The following is a description of a gene set: Human Gene Set: GSE2770_UNTREATED_VS_ACT_CD4_TCELL_2H_DN Th1 and Th2 cells arise from a common precursor cell in response to triggering through the TCR and cytokine receptors for IL-12 or IL-4. This leads to activation of complex signaling pathways, which are not known in detail. Disturbances in the balance between type 1 and type 2 responses can lead to certain immune-mediated diseases. Thus, it is important to understand how Th1 and Th2 cells are generated. To clarify the mechanisms as to how IL-12 and IL-4 induce Th1 and Th2 differentiation and how TGF-beta can inhibit this process, we have used oligonucleotide arrays to examine the early polarization of Th1 and Th2 cells in the presence and absence of TGF-beta after 0, 2, 6 and 48 hours of polarization. species: Homo sapiens Genes down-regulated in CD4 T cells: untreated (0h) versus activated by anti-CD3 and anti-CD28 (2h). from publication Lund R, Aittokallio T, Nevalainen O, Lahesmaa R (PMID 14607935), and this is the list of marker genes: PSMD3, PHKA1, DRG1, PELP1, FGFBP3, PCBP1, KLHL23, TSEN2, KCNK5, PAICS, KSR1, TANGO2, ANGPTL4, MTHFD1, PPIE, CCT3, SLX4, TERF1, SCRN3, FER, ARMCX2, DNAAF2, PRELID3B, CSTF3, E2F2, RTCA, NDUFAF7, NHP2, DPP9, DENND4C, HPS6, PSMC2, PEX2, EWSR1, SLC35F2, FAM83G, MSANTD4, UBA3, MEGF10, EXOSC10, GPHN, UBAP1, PARL, EIF4G2, MESD (NCBI Gene Id 23184), TFG, FARP2, AARS1, PDSS2, CAPRIN1, NUP58 (NCBI Gene Id 9818), SUCLG2, ABCG4, ZNF365, AHI1, GCOM1, CHST1 (carbohydrate sulfotransferase 1), TADA2A, DDX1, TUBGCP6, LMAN1, HYOU1, ZBTB45, SREBF1, RAD50, FYTTD1, IFNLR1, MAP7D1, ATXN10, SAMD1, DCAKD, CBX4, GNG3, ENOPH1, IFT57, FUBP3, ZNF746, C19orf47, METTL5, AKR1E2, SUCLA2, SMARCB1, KLRC1, WDSUB1, SCN11A (NCBI Gene Id 337933), TSFM, SRM, MRFAP1L1, WDR90, LRRC14, TBC1D7, HMGA1 (NCBI Gene Id 3159), RPGR, ZNF623, SMG5, AHCY, SRBD1, SUMO3, SARNP, ZNF235, TTC9C, RBBP5, GGT7, STIM2, FHOD3, GEMIN5, TMEM205, HNRNPM, HDAC2, C2orf49, PJA1 (NCBI Gene Id 64219), MRPS31, MYBBP1A, ARHGEF12, PPWD1, PARK7, IFT74, TRMT61A, BCAR1, TMEM164, PKP2, DLAT, DCAF13, MIF, USP37, CRPPA, PALS2, DNAL1, ACSL5, E2F4, TIGAR, NUDCD1, TMBIM1, MXD3, LAP3, TTLL4, PPIP5K1 (diphosphoinositol pentakisphosphate kinase 1), RCAN3, DKC1, TOMM6, CEP290, SMAD1, RAD23A, MIGA1, ERGIC1, FEM1B, DBN1, NLRX1, FAF1, KATNB1, SATB2, CELSR2, VPS4A, ELK3, FABP5, C21orf58, ARHGAP33, ACTR8, TIRAP, MTRF1L, MRPL39, PGD, EFTUD2, GCA, OXNAD1, MRPS2, YTHDF2, ABR, NDE1, NXF2, KEAP1, CEP70, POMGNT1, MICU2, WEE1, MANF, YBX2, WDR36, TMEM100, DDX11 (NCBI Gene Id 93260), TM4SF5, CPT2, USP39, RBM14, ACACA (acetyl-CoA carboxylase alpha), ZNF48, DDB1, TTLL12, WDR12, DMRT2, IGF2BP3, TUSC1, TSEN54, TLNRD1, GLCE, LY75, BPNT2, TUBGCP2, SLC2A2, TONSL